The following is a description of a gene set: species: Homo sapiens Neoplasm of the middle ear Human Gene Set: HP_NEOPLASM_OF_THE_MIDDLE_EAR A tumor (abnormal growth of tissue) of the middle ear., and this is the list of marker genes: KMT2D, FOCAD, NKX2-1, SIX1, APC2, NSD1, NFIX, DDR2, EYA1, KDM6A, COG1, SYK